The following is a description of a gene set: species: Homo sapiens Human Gene Set: GSE2770_UNTREATED_VS_IL4_TREATED_ACT_CD4_TCELL_6H_UP Th1 and Th2 cells arise from a common precursor cell in response to triggering through the TCR and cytokine receptors for IL-12 or IL-4. This leads to activation of complex signaling pathways, which are not known in detail. Disturbances in the balance between type 1 and type 2 responses can lead to certain immune-mediated diseases. Thus, it is important to understand how Th1 and Th2 cells are generated. To clarify the mechanisms as to how IL-12 and IL-4 induce Th1 and Th2 differentiation and how TGF-beta can inhibit this process, we have used oligonucleotide arrays to examine the early polarization of Th1 and Th2 cells in the presence and absence of TGF-beta after 0, 2, 6 and 48 hours of polarization. from publication Lund R, Aittokallio T, Nevalainen O, Lahesmaa R (PMID 14607935) Genes up-regulated in CD4 T cells: untreated (0h) versus activated by anti-CD3 and anti-CD28 and then stimulated by IL4 (6h)., and this is the list of marker genes: LYRM4, CMTM3, PPP1R1C, PURG, YPEL3, YAE1, MMD, ARSG, CLU, FKBP9, RDH10, PRPS1L1, PPP1R14B, SLC15A4, KPLCE, AAMP (NCBI Gene Id 14), RHOB, DHRS3, UBXN6, MTPN, ANXA3, MYH4, LMO2 (NCBI Gene Id 8051), SARAF, RNASE4, DCTN2, HGSNAT, STMN1, SBDS, NOD1, RAB23, SPPL2A, PIP4K2A, MTFR1L, HYPK, CLN3, TJP3, TMEM64, BRI3BP, HSD17B8, XPC, NMB, FST, TSN, ISG20, PCBP4, SRI, F11R, MAP1LC3A, ALG11, PRR5L, RELT, RNASEK, CUL4B, TPRG1L, CDK2AP2, SCRG1 (NCBI Gene Id 11341), LCA5, NABP2, GCNT3, PTTG1IP, BSCL2, TMEM106B, STX3, KLHL6, RABAC1, SMPDL3A, FHL5, TADA3, MTMR10, NXPE3, ENPP3, IGIP, EZH1, GNB5, IGFBP6 (insulin like growth factor binding protein 6), PURA, GATM, ABHD17A, AIFM2, FOXD3, TRPT1, FUT7, SSH3 (NCBI Gene Id 82340), NOXRED1, MVP, SMAD1, WARS1, LSM14B, ATP6AP1, CIR1, TBXAS1, STK39, RRM2, UNC119, RBM43, FUBP3, PKP3, CCDC12, AP1S3, RNF215, TRHR, KPNA3, TULP4, CCDC126, ALDH4A1, IDS (NCBI Gene Id 3423), RABGAP1, STARD7, SLC29A1, RAP2A, PNPLA6, ARID5A, LRRC28, TK2, AMBP (NCBI Gene Id 259), KLHL12, PSEN2, FBXW2, FBXO9, ASCC1, FMO5, ATP6V0D1, SIGLEC10, ABCF1, SNX24, RNF14, BNIP3L, VPS26B, CD38, RCOR2, TST, ATP5F1D, IPO11, INPP5B, NOP53, DACT2, TSHR, TYROBP, NDRG1, FFAR2, OGFRL1, GNS, FCGR3A, IKZF4, BTD (biotinidase), ARMC3, ALDH1L2, PANX1, IGHM, LAMC1, CTSV, FBXO8, ACADL, SEH1L, ABTB1, KRT80, BCL7B, HK3, MPP1, NLRP12, CRTAC1, ILK, FBXO3, ATP10D, ESM1, SLC39A1, HPSE, OASL, NDUFV3, TBC1D17, MUSTN1, RHOT2, ZC3H12D, GPLD1, C9orf72, MDGA2, LMOD2, SQOR, C19orf38, PI4K2B (phosphatidylinositol 4-kinase type 2 beta), PTPN22, PTMS, TRIM11, KLC4, SLPI, GALNT7, ZMYM5, ZBTB41, MT2A, SELL, TAX1BP3, PROS1, SOAT2, RPS6KB2, LRRC20, CD248, OAZ2, PARP9, RGS5